The following is a description of a gene set: RNA Polymerase II Pre-transcription Events studied in species Mus musculus Mouse Gene Set: REACTOME_RNA_POLYMERASE_II_PRE_TRANSCRIPTION_EVENTS, and this is the list of marker genes: Polr2g, Mnat1, Iws1, Ctr9, Taf7, Tbp, Taf11, Supt16, Aff4, Taf4b, Polr2c, Cdk9, Polr2i, Ccnt1, Polr2a, Taf5, Ak6, Taf13, Leo1, Polr2d (polymerase (RNA) II (DNA directed) polypeptide D), Eaf1, Mllt3, Taf10, Ncbp1, Gtf2e1, Taf3, Mllt1, Ccnt2, Taf15, Paf1, Tcea1, Gtf2b, Polr2e, Ercc2, Polr2k, Nelfcd, Gtf2h5, Ercc3, Gtf2a2, Supt6, Gtf2e2, Cdc73, Ell, Taf2, Polr2b, Gtf2h4, Gtf2f1 (general transcription factor IIF, polypeptide 1), Skic8, Eaf2, Supt5, Ccnk, Taf6, Nelfe, Ccnh (NCBI Gene Id 66671), Ssrp1, Taf9b, Taf9, Taf1, Eloc, Polr2f, Taf12, Elob, Polr2h, Taf4, Eloa, Gtf2h3, Cdk7, Ncbp2, Gtf2h2, Supt4a, Nelfa, Gtf2h1, Ctdp1, Gtf2a1, Gtf2f2, Nelfb, Polr2l